Given this list of marker genes SAMD9L, IFIT2, TNFSF10, ALDH8A1, HSH2D, TAF15, RASGRP1, NEXN, XAF1, USF1, ATP8A1, CXCL11, MYH3, RIGI, PF4 (platelet factor 4), TLR3, CD38, CD160, here is a description of the gene set: Genes up-regulated in peripheral blood mononuclear cell 24h vs 0h in adults (18-45) (non-responders (previously immunized)) after exposure to Live attenuated vaccine TC-83, time point 24H. Comment: initial exposure 2-10 months before PBMCs drawn. significant genes chosen for membership in canonical pathways Human Gene Set: ERWIN_COHEN_PBMC_TC_83_AGE_18_45YO_NON_RESPONDERS_PREVIOUSLY_IMMUNIZED_24HR_DEG_CANONICAL_PATHWAY_MEMBERS_UP species: Homo sapiens Venezuelan equine encephalitis virus (VEEV) is a positive-strand RNA Alphavirus endemic in Central and South America, and the causative agent of fatal encephalitis in humans. In an effort to better understand the mechanisms of infection, including differences between people who produce a neutralizing antibody response to the vaccine and those who do not, we performed whole genome transcriptional analysis in human PBMCs exposed in vitro to the live-attenuated vaccine strain of VEEV, TC-83. We compared the molecular responses in cells from three groups of individuals: naive; previously vaccinated individuals who developed a neutralizing antibody response to the vaccine (responders); and those who did not develop a neutralizing antibody response to the vaccine (nonresponders). Overall, the changes in gene expression were more intense for the naive group after TC-83 challenge and least potent in the nonresponder group. The main canonical pathways revealed the involvement of interferon and interferon-induced pathways, as well as toll-like receptors TLR- and interleukin (IL)-12-related pathways. HLA class II genotype and suppression of transcript expression for TLR2, TLR4 and TLR8 in the nonresponder group may help explain the lack of vaccine response in this study group. Because TL3 and TLR7 transcripts were elevated in all study groups, these factors may be indicators of the infection and not the immunological state of the individuals. Biomarkers were identified that differentiate between the vaccine responder and the vaccine nonresponder groups. The identified biomarkers were contrasted against transcripts that were unique to the naive population alone upon induction with TC-83. Biomarker analysis allowed for the discernment between the naive (innate) responses; the responder (recall) responses; and the nonresponder (alternative) changes to gene transcription that were caused by infection with TC-83. The study also points to the existence of HLA haplotypes that may discriminate between vaccine low- and high-responder phenotypes. from publication Erwin-Cohen R, Porter A, Pittman P, Rossi C, Dasilva L (PMID 22617845)